Given this list of marker genes MAP3K7, TRAF6, ERN1, SASH1, MAP4K2, TLR6, MAP3K4, TAOK3, ARHGEF5, TNF, PTPN1, TRAF2, MAP3K5, MAP3K11, MAP3K10, here is a description of the gene set: studied in species Homo sapiens Human Gene Set: GOBP_POSITIVE_REGULATION_OF_JUN_KINASE_ACTIVITY Any process that activates or increases the frequency, rate or extent of JUN kinase activity.